The following is a description of a gene set: from publication Sengupta S, den Boon JA, Chen IH, Newton MA, Dahl DB, Chen M, Cheng YJ, Westra WH, Chen CJ, Hildesheim A, Sugden B, Ahlquist P (PMID 16912175) To identify the molecular mechanisms by which EBV-associated epithelial cancers are maintained, we measured the expression of essentially all human genes and all latent EBV genes in a collection of 31 laser-captured, microdissected nasopharyngeal carcinoma (NPC) tissue samples and 10 normal nasopharyngeal tissues. Global gene expression profiles clearly distinguished tumors from normal healthy epithelium. Expression levels of six viral genes (EBNA1, EBNA2, EBNA3A, EBNA3B, LMP1, and LMP2A) were correlated among themselves and strongly inversely correlated with the expression of a large subset of host genes. Among the human genes whose inhibition was most strongly correlated with increased EBV gene expression were multiple MHC class I HLA genes involved in regulating immune response via antigen presentation. The association between EBV gene expression and inhibition of MHC class I HLA expression implies that antigen display is either directly inhibited by EBV, facilitating immune evasion by tumor cells, and/or that tumor cells with inhibited presentation are selected for their ability to sustain higher levels of EBV to take maximum advantage of EBV oncogene-mediated tumor-promoting actions. Our data clearly reflect such tumor promotion, showing that deregulation of key proteins involved in apoptosis (BCL2-related protein A1 and Fas apoptotic inhibitory molecule), cell cycle checkpoints (AKIP, SCYL1, and NIN), and metastasis (matrix metalloproteinase 1) is closely correlated with the levels of EBV gene expression in NPC. Genes down-regulated in nsopharyngeal carcinoma relative to the normal tissue. Human Gene Set: SENGUPTA_NASOPHARYNGEAL_CARCINOMA_DN species: Homo sapiens, and this is the list of marker genes: GIHCG, CES1, CYP4B1, VWA3B, FUT2, TEKT1, MT1E, SNTN, MSMB, B3GNT7, CXXC5, MORN3, PIERCE1, MUC1, TTC9, CDHR3, ECRG4, DRC1, DHCR24, SCGB2A1, TUBB2A, CLDN23, S100P, CXCL1, RASSF1, LRRC34, SERPINB3, RBM24, POR, GSTA3, IFTAP, TSPAN6, NBEA, ELF3, MS4A8, SAPCD1-AS1, CIB1, AKAP14 (A-kinase anchoring protein 14), C19orf33, PACRG, HOATZ, DNAH9, CCDC81, TNFSF11, TJP3, KRT4, AKR1C3, GCLM, MIR34B, EP300-AS1, PTPRN2, FBXO15, ABHD14B, CSTB, PLCE1, FMO5, BANK1, LZTFL1, IQCD, OMG, CFAP45, TEKT2, CATSPERD, WDR13, ODAD4, EPPK1, SMDT1, FOXJ1, PCP4L1, ATP10B, SPAG6, SAA1, CRYL1, CR1, TUBA4B, EZR, CLDN7, BNIPL, PIGR, MAP3K19, FAM174B, BPIFB1, DMKN, CCDC17, ARSD, DNAI7, DNAI4, MUC20, PAX5 (paired box 5), AQP3, C11orf52, KLF8, CHST9, SELENBP1, BACE2, ALDH3B2, CCDC181, ENSG00000280119, VILL, TLCD2, BCO2, CCDC190, SERPINB7, ALOX15, KCNE1, P4HTM, LCN2, CD19, CFAP161, SPAG17, ELL3, SERPINB4, PROM1, KATNB1, ZFYVE21, DNAL1, PSENEN, ZBBX, PPIL6, AGBL2 (AGBL carboxypeptidase 2), SLC22A4, MS4A1, SERPINB6, INAVA, DNAH7, CIMIP2B, LRRC10B, EPB41L4B, DNAAF4, TMEM45B, TCL1A, IQCA1, LTF, CCDC65, TCEA3, CLIC6, SCGB1A1, RSPH9, DYNLT5, B9D1, CRACDL, AHNAK2, TSGA10, CHD9NB, PLAAT2, CC2D2A, CFAP206, ANKRD35, AK7, ABCA13, IMPA2, C1orf116, CR2, SIX2, TMEM190, SPMIP6, TMEM231, MGLL, EPPIN (NCBI Gene Id 57155, epididymal peptidase inhibitor), CFAP52, CAPN9, WFDC2, POU2AF1, MDH1B, CFAP43, MUC13, IFT57, CAPS, ST6GALNAC1, UBXN10 (NCBI Gene Id 127733), WDR54, SPA17, TMC5, RIBC1, AK9, KRT7, C1orf87 (chromosome 1 open reading frame 87), SMIM22, VPS37B, TRIM7, RRAD, CLDN10, CFAP95, SLPI, EML6, RSPH4A, CFAP276, LRRIQ3, EFHC1, C11orf97, RHOV, CIMAP3, ZMYND12, CFAP263, ERICH3, NMU, FKBP1B, KRT14, TUBB4B, ANKRD37, ABLIM1, NEK5, NQO1, ATP12A, PTGR1, LRP11, CLIC3, TPPP3, CLXN, DNAAF1, CGN, ASS1, AGR2, PRR15, TTC21A, BBOF1, CFAP53, PIAS3, DYNLRB2, SPATA33, TTC29, CETN2, TSPAN1, CIMIP1, DNAI2, ROPN1L, RSPH3, ADH1C, VTCN1, SYBU, CCNO, ALDH1L1, DNAAF6, PRR18, CD55, ODAD1, SPATA17, TMPRSS4, CFAP126, PLCG2, DNAH12, TNFRSF13C, CIMAP1B (ciliary microtubule associated protein 1B), TFF3 (NCBI Gene Id 7033), S100A9, DNAH10, CABCOCO1, MORN5, DNAH5, SORBS2, CFAP90, FAM229B, SPATA18, ADIRF (NCBI Gene Id 10974), TMEM154 (transmembrane protein 154), TRAF3IP1, TOGARAM2, SPEF2, FAM81B, RSPH1, ENKUR, FCRLA, DAW1, GON7, RSPH10B, SLC22A16, CKB, FAM131A, IFT172, MORN2, VWA5A, SPAG1, LRG1, CFAP299, VNN3P, TOX3, ARMC3, TRIM13, C6orf118, PRSS23, DNAI3, RALGPS2, ERICH5 (NCBI Gene Id 203111), BASP1, FAM216B, PI3, DNAJA4, FANK1, ZNF667-AS1, DNALI1, KLHDC9, DNAI1, IL20RA, NEK11, ANXA11, TEX9, ARMC2, COBL, GRHL2-DT, ENSG00000258752 (novel transcript, antisense to FOXN3), MIR449A, FAM149A, EFHB, GSTA1, CFAP300, DUOX1, TPPP, CCDC74A, SYNGR1, TMEM40, TTC12, CFAP251, SLC2A10, RIBC2, DNAH2, EFCAB2, HYDIN, OSCP1, FAM3D, TNFRSF21, DRC3, ADSS1, CFAP47, H2BC21, CAPSL, MUC16, PDZK1IP1, VPREB3, SLC16A5, SAXO2, TACC2, ADGRF1, CFAP210, C7orf57, UPK1B, TMC4, PIH1D2, CFB, SMIM5 (small integral membrane protein 5), CAPN5, CFAP184, SMIM34, ALDH3B1 (NCBI Gene Id 221), SLC44A4, IQCG, SYTL4, CDH26, STOML3, ODAD2, TUBA1A (tubulin alpha 1a), PRDX5, MYO1D, TRAK1, DNER, PRDX1 (peroxiredoxin 1), MUC4, SLC27A2, MFSD4A, FAM3B, CHST6, EVA1C, SRGAP3-AS2